The following is a description of a gene set: Reactome Pathway: Amplification of signal from the kinetochores A single unattached kinetochore is capable of preventing cells from exiting mitosis. The mitotic checkpoint provides a way for a localized defect to affect the global biochemical status of the cell. In principle, the signal that is generated at an unattached kinetochore diffuses throughout the cell to affect its target. There are currently two models for how this is achieved. One model is based on the observation that the Mad2 checkpoint protein binds and is rapidly released from unattached kinetochores. The kinetochore is believed to act as a catalyst that converts Mad2 into an inhibitory state that diffuses throughout the cell upon its release from the kinetochore. A second model proposes that the signal is amplified by a kinase cascade much like a conventional signal transduction pathway. This kinase cascade is believed to be comprised of the checkpoint kinases, hBUBR1, hBUB1, hMPS1. part of: Mitotic Spindle Checkpoint studied in species Homo sapiens, and this is the list of marker genes: NUF2 (NCBI Gene Id 83540), PPP2R5E, PPP1CC, SEC13, NUP37, CLASP1, CENPC, BIRC5, ERCC6L, AURKB, SKA1, SPC25, NUP85, NUP43, CENPN, ZWILCH, PPP2R1A, KNTC1, DYNC1H1, AHCTF1, CLIP1, NUP107, PPP2R5B, CENPU, NUP98, CENPI, PPP2R1B, DYNC1I2, NDEL1, MAD2L1 (mitotic arrest deficient 2 like 1), DYNLL1, PMF1, KNL1, CDC20, BUB1, XPO1, CENPE (NCBI Gene Id 1062), DYNLL2, PPP2CA, B9D2, MAPRE1, MIS12, KIF2C, SEH1L, CENPA, PAFAH1B1, ZWINT, KIF18A, NDE1, NDC80, INCENP, SPC24, ITGB3BP, CENPF, PLK1, SPDL1, CDCA8, NUP160, PPP2R5A, CENPL, RCC2, CENPK, CKAP5, RPS27, TAOK1, DSN1, DYNC1LI2, RANGAP1, SGO2, ZW10, CENPH (NCBI Gene Id 64946), DYNC1I1, DYNC1LI1, PPP2R5D, MAD1L1, KIF2A, NSL1, SKA2, BUB1B, CENPT (NCBI Gene Id 80152), CENPP, NUP133, CENPS, CENPQ (NCBI Gene Id 55166), CLASP2 (NCBI Gene Id 440948), BUB3, PPP2R5C, CENPM, KIF2B, RANBP2, PPP2CB, CENPO, SGO1, NUDC